The following is a description of a gene set: The chemical reactions and pathways involving L-phenylalanine, the L-enantiomer of 2-amino-3-phenylpropanoic acid, i.e. (2S)-2-amino-3-phenylpropanoic acid. Mouse Gene Set: GOBP_L_PHENYLALANINE_METABOLIC_PROCESS species: Mus musculus, and this is the list of marker genes: Pcbd1 (NCBI Gene Id 13180), Tat, Spr, Fah, Il4i1, Gstz1, Qdpr, Hgd, Hpd, Pah